The following is a description of a gene set: studied in species Mus musculus Mouse Gene Set: GOBP_EMBRYONIC_CAMERA_TYPE_EYE_DEVELOPMENT The process occurring during the embryonic phase whose specific outcome is the progression of the eye over time, from its formation to the mature structure., and this is the list of marker genes: Kdm2b, Aldh1a1, Arid1a, Sox11, Stra6, Cryaa, Rarg, Twist1, Lrp6, Wdr19, Tfap2a, Bmp7, Rdh10, Prox1, Th, Six3, Ihh, Sp1, Ppp1r13l, Tulp3, Sp3, Hipk1, Cdk20, Pax6, Cited2, Nes, Traf3ip1, Pitx2, Rara, Hipk2, Tbx2, Fzd5, Ift122, Phactr4, Pax2, Ift172, Ift140, Aldh1a2, Fgf10 (fibroblast growth factor 10), Zeb1, Foxf2, Aldh1a3, Frs2